The following is a description of a gene set: Genes within amplicon 10q22 identified in a copy number alterations study of 191 breast tumor samples. from publication Nikolsky Y, Sviridov E, Yao J, Dosymbekov D, Ustyansky V, Kaznacheev V, Dezso Z, Mulvey L, Macconaill LE, Winckler W, Serebryiskaya T, Nikolskaya T, Polyak K (PMID 19010930) A single cancer cell contains large numbers of genetic alterations that in combination create the malignant phenotype. However, whether amplified and mutated genes form functional and physical interaction networks that could explain the selection for cells with combined alterations is unknown. To investigate this issue, we characterized copy number alterations in 191 breast tumors using dense single nucleotide polymorphism arrays and identified genes with copy number gain organized into 30 amplicons. Amplicons were distributed unequally throughout the genome. Each amplicon had distinct enrichment pattern in pathways, networks, and molecular functions, but genes within individual amplicons did not form coherent functional units. Genes in amplicons included all major tumorigenic pathways and were highly enriched in breast cancer-causative genes. In contrast, genes with somatic mutations in breast cancer were distributed randomly over the genome, did not represent a functionally cohesive gene set, and were relatively less enriched in breast cancer marker genes. Mutated and gained genes did not show statistically significant overlap but were highly synergistic in populating key tumorigenic pathways including transforming growth factor beta, WNT, fibroblast growth factor, and PIP3 signaling. In general, mutated genes were more frequently upstream of gained genes in transcription regulation signaling than vice versa, suggesting that mutated genes are mainly regulators, whereas gained genes are mostly regulated. ESR1 was the major transcription factor regulating amplified but not mutated genes. Our results support the hypothesis that multiple genetic events, including copy number gains and somatic mutations, are necessary for establishing the malignant cell phenotype. Human Gene Set: NIKOLSKY_BREAST_CANCER_10Q22_AMPLICON studied in species Homo sapiens, and this is the list of marker genes: RPS24, ZMIZ1, KCNMA1, POLR3A, PPIF, EIF5AL1, DLG5, ZCCHC24